The following is a description of a gene set: species: Homo sapiens Human Gene Set: chr7p22, and this is the list of marker genes: TMEM184A, ZFAND2A-DT, OR7E136P, ENSG00000239715, ELFN1, MRM2, ENSG00000217455, SMIM10L3, RN7SL851P, CCZ1B, RBAK-RBAKDN, INTS15, RPL22P16 (NCBI Gene Id 100270959), MIR6874, USP42, RSPH10B, GPER1, LFNG, IMMP1LP3, PMS2CL, ENSG00000287342, PRKAR1B-AS2, RPSAP73, AMZ1, ENSG00000293573, DAGLB, ENSG00000231476 (novel transcript), RNU6-215P, PSMG3, PSMG3-AS1, PDGFA-DT, PRKAR1B-AS1, CARD11-AS1, SLC29A4, MICALL2, FAM86LP, FAM157D, EIF2AK1, SPDYE20P, IQCE, OR7E39P, PMS2, CARD11 (NCBI Gene Id 84433), LNCRI, DNAAF5, RSPH10B2, LINC03073, TTYH3, TFAMP1, ALG1L5P, FOXL3, BRAT1, MIR4648, RPL31P34, ELFN1-AS1 (NCBI Gene Id 101927125), SDK1-AS1, KIF19BP, ZNF890P, RPL21P72, LINC02983, OR7E59P, EIF3B, RNU6-218P (RNA, U6 small nuclear 218, pseudogene), AP5Z1, CYTH3, MAD1L1, MAFK, ENSG00000289352, ANKRD61, ZNF815P, TNRC18, MIR339, CCZ1, FSCN1, RN7SKP130, SNX8, SNORA80D, KDELR2, ZNF316, PAPOLB, FAM20C, ENSG00000224079, GNA12, SUN1, FBXL18, C1GALT1, PRKAR1B, GET4, ADAP1, LINC03015 (NCBI Gene Id 102723672), GPR146, ENSG00000249574, MIR6836, RNF216-IT1, ZNF853 (zinc finger protein 853), OCM, RBAKDN, ACTB, RADIL, CHST12, SDK1, OR10AH1P, AIMP2 (NCBI Gene Id 7965), COX19, MICALL2-DT, ZDHHC4, CYP3A54P, RNF216P1, NUDT1, FAM220A, ZNF12, UNC93B2, GRIFIN, MIR4655, CYP2W1, MMD2, EVA1CP3 (EVA1C pseudogene 3), WIPI2, NGRNP3, INTS1, RNF216 (ring finger protein 216), MIR589, UNCX, LINC03014, ENSG00000299792, ZFAND2A, C7orf50, RAC1, GRID2IP, RN7SL556P, MIR4656, FOXK1, MIR3683, RBAK, ENSG00000286710, SPDYE19P, ENSG00000232581, PDGFA, ENSG00000242611